Given this list of marker genes Ccdc14, Eif1, Phip, Cep57, Ppm1e, Sowahc, Nab1, Tle4, Phf6 (PHD finger protein 6), Arl6ip1, Atp11c, Dnajc5b, Lrch2, Ncam2, Vwa8, Syde2, Rad51d, Fgf14, Pogk, Ube2e3, Cdh8, Nanp, Tgfbr1, Bclaf1, Itsn1, Snip1, Usp2, Setdb2, Sptssa, Rap2c, Ldb3, Dnm1l, Ccnc, Rnf152, Trim23, Ppp1r14c, Patj, Rnf115, Tmeff1, Fubp1, Lrrn3, Jade1, Bcl2 (NCBI Gene Id 98734), Epha7, Prox2, Jazf1, Fam168b, here is a description of the gene set: species: Mus musculus from publication Chen Y, Wang X (PMID 31504780) Mouse Gene Set: MIR_3102_3P.2_3P Genes predicted to be targets of miRBase v22 microRNA mmu_miR_3102_3p.2_3p in miRDB v6.0 with MirTarget v4 prediction scores > 80 (high confidence targets).